The following is a description of a gene set: Genes up-regulated in CD4 T cells activated by anti-CD3 and anti-CD28: TGFB1 and IL-12 (2h) versus untreated (2h). Human Gene Set: GSE2770_IL12_AND_TGFB_ACT_VS_ACT_CD4_TCELL_2H_UP species: Homo sapiens from publication Lund R, Aittokallio T, Nevalainen O, Lahesmaa R (PMID 14607935) Th1 and Th2 cells arise from a common precursor cell in response to triggering through the TCR and cytokine receptors for IL-12 or IL-4. This leads to activation of complex signaling pathways, which are not known in detail. Disturbances in the balance between type 1 and type 2 responses can lead to certain immune-mediated diseases. Thus, it is important to understand how Th1 and Th2 cells are generated. To clarify the mechanisms as to how IL-12 and IL-4 induce Th1 and Th2 differentiation and how TGF-beta can inhibit this process, we have used oligonucleotide arrays to examine the early polarization of Th1 and Th2 cells in the presence and absence of TGF-beta after 0, 2, 6 and 48 hours of polarization., and this is the list of marker genes: PDGFA, NLRP2, PIK3R5, HIP1, EMILIN1, TPP2, ABCC1, SACS, TMCO3, TARDBP, LASP1, KMO (kynurenine 3-monooxygenase), FUS, CES1, RBM14, ATP13A3-DT, ZNF597 (zinc finger protein 597), PSMD7, DOLK, PALLD, PLPP5 (phospholipid phosphatase 5, NCBI Gene Id 84513), MGLL, HSP90AA1, RAB7A, EEIG1, LINC00622, VDAC3, TMEM208, AGAP3, SMG6, TDP2, FTL, ZBTB45, HSPH1, ZNF274, PGD, STK17A, PSMD14, H2BC11, ZNF557, HPDL, APOL4, VCP, RAD1, ODR4, TMEM138, RHEB, RUNX1 (RUNX family transcription factor 1), TEX10, JPT2, CTNS, ZNF667, TNIP1, GTF3C4, RNASEK, EIF4ENIF1 (NCBI Gene Id 56478), EPHA5, LRP12, RNF185, PSMD11, DNAJB11, SPINK1, KIF1B, TJP2, ITGA5, EPOP, SNX9, STX3, FADD, NCOA3, HOPX, CD2BP2, CYP1B1, SSH1, HSD11B1, MED8, CCRL2, MRPL27, PHF23, S1PR2, SART3, LINS1, PAFAH1B1, LEO1, DNAJC6, GNPDA2, TNFRSF18, PPARD, MOB3C, SAV1, GPR35, IL18BP, MSC, APBA3, RAPGEF1, TMEM199, DCAF1, FEN1, RBM10, IER5L, NIBAN2, FLVCR2 (NCBI Gene Id 55640), SDF4, CD63, PSMD1, NRBP1, SLC26A11, HEXIM1, DNAJB6, ZNF37A (NCBI Gene Id 7587), APOL2, HSPB1, ZNF189, PPIL1 (NCBI Gene Id 5482), MLLT6 (NCBI Gene Id 4302), RASL10A, AREL1, C3, APEX2, C17orf58, ZMIZ1-AS1 (NCBI Gene Id 283050), SDC4, CYP51A1 (NCBI Gene Id 1595), IL24, PDXK, ACOT13, AP3D1, TSPAN33, AKR1B1, HAS1, HPD, VEGFB, NIPAL1, NMRAL2P, PSMA3, TM2D2, NPC1, TRAF3, CDKN1A, CASS4, IPO9, SPAG9, GAS2L3, SH3BP5L, IL2RG, GSR, MSMO1, BMP5, ST13, KCNK6, PI4K2A, KEAP1, SLC12A6, ITGAX, IST1, CCDC127, ALOX15, ATP6V0B, PHF13, LPAR1, LEMD2, YAE1, GCLM, BRD8, GADD45G, PSAPL1, KYNU, ZNF410, NSMAF, LMNA, ACSL3, IL3RA, ZFYVE1, GON4L, ACTR1A, DYNLL1, SIGLEC17P, ABCC3, TMED9, SDHAP2, CC2D1B, ZNF200, ZNF697, E2F6, ZMIZ1, HSPA8, LINC00926 (long intergenic non-protein coding RNA 926), TCTN1, LRRC52, METTL1, STX4, EYA3, TUBB6, NMT2, TRIO, DNAJA1, EML4